The following is a description of a gene set: Human Gene Set: HP_MACULAR_HYPERPIGMENTATION Increased amount of pigmentation in the macula lutea. studied in species Homo sapiens Macular hyperpigmentation, and this is the list of marker genes: CRX, CFH, PAX2, CDH3, EFEMP1, ADAR (adenosine deaminase RNA specific), CFI